The following is a description of a gene set: Human Gene Set: HP_HEPATIC_ENCEPHALOPATHY Central nervous system dysfunction in association with liver failure and characterized clinically (depending on degree of severity) by lethargy, confusion, nystagmus, decorticate posturing, spasticity, and bilateral Babinski reflexes. Hepatic encephalopathy species: Homo sapiens, and this is the list of marker genes: TNPO3, TNFSF15, POU2AF1, IL12A, JAK2, TULP3, F5, NBAS, CALR, SLC25A13, ZNFX1, DLD, XIAP, RYR1, EIF2AK3, ALMS1, RINT1, IL12RB1, FOCAD, SPIB, PCK1, MMEL1, IRF5, SH2D1A